Given this list of marker genes Ctnna1, Cap1, Sema6c, Il23a (interleukin 23, alpha subunit p19), Asb2, Gpc1, Emx2, Schip1, Adipoq, Slamf1, Rhoa, Cxcl16, Gnai1 (G protein subunit alpha i1), Idh2, C5ar1, Efnb2, Ephb4, Mcu, Chl1, Lgmn, Plekhg3, Lefty1, Hhipl1, Spred1, Camk2a, Tpm1, Meak7, Park7, Adam15, Prkg1, Strip2, Fbn2, Itgav, Ada, Nox1, Cd200, Fgf3, Ntrk3, Cldn4, Pbxip1, Fndc3b, Prcp, Angpt4, Agtr1a, F11r, Bex6 (NCBI Gene Id 547261), Pdgfc, Anln, Phldb2, Trim32, Ccn4, Lurap1 (leucine rich adaptor protein 1), Gli1, Gba1, Dusp3, Wwc1, Igfbp3, Jun, Gp1ba, Itgb4, Tbx21, Rps19, Sema7a, Iqgap1 (IQ motif containing GTPase activating protein 1), Scrt2, Foxf1, Itga1, Capn1, Parva, Arf6, Gpc4, Fat3, Cnn2, Asap3, Ptp4a3, Tmsb15a, Dcx, Ccl21d, Rap2c, Calr, Plk2, Prkci, Gpr18, Kirrel3, Ptpru, Ntng2 (netrin G2), Epha1, Cep85l, Vegfb, Stc1, Pdgfa, Gm6040, Ifng, Pcdha9, Mmp7, Cln3, Ninj1, Scarb1, Dmrt1, Ddrgk1, Cck, Rarres2, Maz, Cbll1, Xcr1, Pdpn, Ffar2, Bmper, AU040320, Sirt1, Prr5l, Cxcl2, Fermt3, Kitl, F2r, Fga, Hace1, Foxo3, Bmp4 (NCBI Gene Id 12159), Tnf, Pou3f2, Serpine1, Eng, Spdl1 (NCBI Gene Id 76404), Mapre1, Nod2, Fbxo45, Arhgdia, Coro1a, Fgf21, Glipr2, Rere, Bax, Nbl1, Stk39, Cspg4, Ccl21e (NCBI Gene Id 100504239), Spag6l, Emp2, Tmigd1, Ccl24, Lrp1, Pla2g7, Fam89b, Cdh26, Mta2, Irak4, Smoc2, Tubb2a (NCBI Gene Id 263448), Vax1, Plxnd1, Neurog2, Rab1a, Fam3d, Eppk1, Lox, Lypd4, Fer, Fscn2, Fbxo41 (NCBI Gene Id 52369), Arpc5, Six4 (sine oculis-related homeobox 4), Fgfr1, Apoh, Setd2, Ptprb, Afdn, Fuz, Prkcq, Ptprm, Krit1, Arhgap4, Alox5, Ptpn22, Map2k1, Smad2, Rcc2, Slk, Prickle1, S100a11, Cdhr18, Emc10, Ccl25, Prl2c2 (prolactin family 2, subfamily c, member 2), Tesk1, Evx1, Abi2, Gab2, Il1b, Mrtfb, Lamb3, Sema3d, Fgf7, Syk, Tcaf1, Mtor, Unk, Dapk3, Tacstd2, Avl9, Reln, Akt2, Lamtor2, Depdc1b, Prkd2, Tlr4, Cdh2, Lamc1, Pik3r3, Tiam1, Met, Erbb4, Vav3, Dnaaf4, Perp, Srp54a, Ccl5, Add2, Ackr4, Spi1, Hnf4a, Gna13, Ttbk2, Lrch1, Igsf10, Ccl21a, Insr, Ulk1, Prkca, Rac1, Ccl19-ps6, Phox2b (NCBI Gene Id 245706), Arhgef5, Pak2, Tert, Pdlim1, Cdh22, Pik3cb, Mia3, Abl2, Adam10, Itga3, Insl3, Itga4, Cxadr, Bmpr1a, Adipor2, Ythdf3, Nckap1 (NCK-associated protein 1), Anxa1, Cass4, Vegfa, Tnfaip1, Ror2, Flt3, Il24, Paxip1, Smim22, Nup62, Pax3, Mctp1, Miip, Il1rn, Cdh8, Ang6, Rufy3, Sinhcaf (SIN3-HDAC complex associated factor), Mst1r, Itgb1bp1, Magi2, Six2, Dock2, Pak3, Retnlg, Sdc4, Rras (NCBI Gene Id 20130), Dchs1, Jcad, Camk2b, Pgr, Gpsm3, Trem1, Limch1, Sirpa, Gpc3, Angptl3, Usp45, Bcl11b, Pip5kl1, Cklf, Cxcl15, Tgfbr3, Ptger4, Tradd, Smpd3, Cdh15, Ntf3, Adipor1, Fat1, Gdf6, Artn, Sin3a, Tor1a, Pik3r1, Mmp14, Golph3, Mertk, Abr, Auts2, Hrg (NCBI Gene Id 94175), Cend1 (NCBI Gene Id 80544), Kiss1, Cd200r1, Ptprj, Crtam, Ccl28, Egfr, Prkcd, Tgfbr1, Cdkl5, Nkx2-3, Sell, Cxcr3, Pde4b, Nedd9, Tet1, Acan, Ackr2, Pex13, Dll4, Naca, Epx, Nars1, Gcnt2 (NCBI Gene Id 78281), Nexmif, Usp17le, Pik3cg, Trim55, Kiss1r, Bcar1, Disc1, Defb47, Tnc, Casp8 (NCBI Gene Id 12370), Akap12, Svep1, Defb6, Epha8, Spag9, Ptprc, Celsr2, Krt16, Sdc3, Cdk5r2, Ilk, Lyn, Cdh19, Dock7, Plvap, Ceacam1, Pou4f1, Rhof, Abcc8, Fcer1g, Vsir (V-set immunoregulatory receptor), Map3k1, Elp6, Mylk, Akt1, Unc5c, Mif, Lhx6, Ptger3, Mstn, Mapk3, S100a2, Arl13b, Prkcz, Gas6, Egfl7, Cdk5, Nrp2, S1pr2, Trpm2, Numb, Tsc2, Smad4 (SMAD family member 4), S2bpcox16, Ptk2b, Lrp6 (NCBI Gene Id 77387), Mst1, Akirin1, Pacsin2, Pard3, Tirap, Plekhg5, Cib1 (NCBI Gene Id 23991), Cdh10, Cer1 (cerberus 1, DAN family BMP antagonist), Stk4, Rac3, Dysf, Cd24a, Camsap3, Ccn3, Pkn2, Agt, Rbbp4, Abcc1, Mcc, Adam17, St14, Tmsb15b2, Gbf1, Fut10 (NCBI Gene Id 171167), Mapk15, Bbs1, Cxcr2, Jaml, Ric8a, Fam107a, Cxcl1, Ddr1, Megf8, Arrb2, Clec7a, Tnfsf11, Rbfox2, Carmil1, Ston1, Rapgef3, Rps6kb1, Rock1, Fam83h, Ggt5, Sema4f, Fas, Sema5b, Cdh23, Ing2, Cldn13, Fam83d, Arf4, Limd1, Acvr1c, Fut8 (NCBI Gene Id 53618), Scrib, Flna, Irs2, Wnt5a, Pml, Gpr183, Prss37, Gpnmb, Brms1, Podn, Notch1, Ccl21b, Lrp5, Apela, Acp5 (NCBI Gene Id 11433), Xcl1, Enpep, Lcp1, Angpt2, Ccl26, Apcdd1, Rhob (ras homolog family member B), Syde2, Lama3, Nr2f2, Sfrp1, Elp3, Akt3, Tnr, Atp1b2, Trip6, Dpep1, Tgfb1, Cdh11, Gdf15, Ddr2, Cd34, Hspb1, Aimp1, Mgat5, Braf (NCBI Gene Id 97330), Rhbdf1, Sema6a, Pld1, Pvr, Gpc2, Cxcr1, Mark1, Thbs4, Mcoln2, Cav1, Foxg1, Olig3, Sox8, Lemd3, Rab25, Kcnn4, Itga6, Tnfsf4, Onecut2, Pdpk1, Msx2, Ptgs2 (NCBI Gene Id 19225), Cdc42bpa, Dreh, Ptk2, Lamb1, Prtn3, Srf, Dcn, Smad3, Gnrh1, Clasp1, Trpv4, Marveld3, Creb3, Bmp2, Camk2d, Pgf, Vhl (von Hippel-Lindau tumor suppressor), Sox10, Fmnl1, Stat5b, Mnx1, Ccrl2, Tnn, Grem1, Bambi, Cdh3, Tyro3, Mitf, Rap2b, Abhd2, Clxn, Dmtn, Pax6, Rtn4, Jam3, Cpne3, Cxcl13, Il6st, Tff2, Mir218-1, Ccl3, Vtn, Epha3 (Eph receptor A3), Zfand5, Hspa12b, Vcan, Rhog, Bag4, Nr4a1, Ctnnd1, Lima1, Tgfbr3l, Pou3f3, Nfe2l2, Ppp2r3a, Fzd3 (NCBI Gene Id 320969), Ccl6, Hdac7, Cyp19a1, Plaa, B4galt1, Usp33, Ripor2, Tbxa2r, Fut1, Dcc, Barhl2, Cldn19, Rab11a, Fscn3, Wwc2, Cort, Atp8a1, P2ry6 (NCBI Gene Id 66545), Hgf, Patz1, Sox9, Ccl21f, Flrt2, Gata3, Dusp1 (NCBI Gene Id 98098), Tmem18, Cx3cr1, Pds5a, Usp9x, Ndn, Top2b, Madcam1, Tmem196, Ccbe1, Wnt11, Lhx1, Il17a, Gsk3b, P2ry12, Gdf2, Cldn3, Cep85, Wdr47, Adora3, Spn, Mecp2, Ang4, Clec14a, Nrg1, P4hb, Ccr8, Sox14, Adgrg1, Ssh2, Spef1, Plat, P2rx4, Adora1, Dock5, Ptpn23, Cdh5, Dab2ip, Osgin1, Lrig2, Sod2, Fubp1, Scnn1g, Atp7a, Pdilt, Mir504, Ccl4, Postn, Dbh, Pip5k1a (phosphatidylinositol-4-phosphate 5-kinase, type 1 alpha), Lpar1, Vangl2, Ezh2, Ccl19, Mcur1 (NCBI Gene Id 76137), Plxnb2, Msn, Cxcr5, Sema3g, Tfap2a, Pmp22, Meox2, Dock4, Xbp1 (X-box binding protein 1), Fgf2, Clasp2, Ccl2, Apex1, Cxcl11, Sp1, Trib1, Mospd2, Fgr, Vcam1, Muc2, Plec, Bmerb1, Ntn1, Reck, Ppbp, Emilin2, Sparc, Lgals9, Cdh18, Ccl19-ps3, Itga9, Hexb, Ptp4a1, Dock8, Thy1, Ccn1, Tbx20, Tac1, Sox17, Nlrp3, Fpr-rs7, Ppargc1a, Amot, Mdga1, Wasf2, Cldn1, Plxnb3, Flt1, Drd4, Fignl2, Cd9, Coro1b, Ndel1, Nfix (NCBI Gene Id 18032), St3gal4, Fat2, Shtn1, Sema3b, Mapre2, Phactr4, Tubb2b, D130043K22Rik, Lmx1b, Crb2, Cntn2, Tafa4 (NCBI Gene Id 320701), Itgb8, Itga2b, Cul5, Sema3e, Flt4, Aoc3, Mmp10, S100a14, Cenpv, Gja1 (gap junction protein, alpha 1), Cxcl5, Ccr7, Rras2, Ednrb, Wdr1, Itgb7, Cdh24, Pdcd6, Cxcl10, Wincr1, Gpx1, Col5a1, Vinac1, Tmigd3, Ddit3, Sphk1, Ogdh, Hyal2, Rnf41, Elp5, Tmem102, Lmo4, Scg2, Cd81, Lrrc15, Hmgb2, Tns3, Mir875, Ptprg, Evl, Cx3cl1, C5ar2, Hc, Trem3, Fktn, Sun2, Ptprf, Ccl11, Il1a, Zpld2, Shroom2, Ace, Rnf7, Pik3r2, Tlx3, Retn, Fut7, Nav1, Ldb2, Foxj1, Uts2 (NCBI Gene Id 24111), Med23, Stap1, Ripor1, Fstl1, Kif2a, Krt5, Pawr, Knstrn, Myoc, Apod, Plet1, Nr2e1, Actr3, Dcdc2a, Nrg3, Acvr1b, Rnf20, Nkx2-1, Plxna3, Gm5849, Igfbp5, Fmn2, Radil, Trim46, Umod, Tafa5, Cd47, Edn3, Prl7d1, Mdm2, Angpt1, Grb7, Cripto, Csnk2b, Zmynd8, Atn1, Cttn, Tacr1, Plekho1, Nrp1, Ptprk, Pde4d, Psen1, Atp5f1b, Lgr6, Sema3f, Plpp3, Egf, Phactr1, Vav1, Dab1, Sh3rf1, Fermt2, Sbpl, Enpp2, Gpc5, Dnai3, Prpf40a, Padi2, Myo1f, Arid2, Hdac4, Fgfr4, Fpr-rs6, Nsmf, Actg1, Defb5, Peak1, Thbs1, Mmp2, Cxcr6, Il16, Slc8b1, Has1, Eomes, Errfi1 (NCBI Gene Id 74155), Emilin1, Rin3, Arsb, Arpin, Mmrn1, Fbxw7, Mrtfa, Lyst, Pten, Mark2, Synpo2, Zfp640, Ptk6, Lbp, Cdh1, Hcls1, Fgf5, Ccl19-ps5, Satb2, Lrg1, Gm266, Apbb2, Ext1, Nck2, Pdgfrb, Igf2, Cxcl9, Synj2bp, Lyve1, Robo1, Macf1, Sp100, Slc8a1, S100a8, Cd74, Six1, Pdgfra, Cnr2, Rnh1, Cxcl14, Cyp7b1, Sap130, Nav3, Dpp4, Card10, Ch25h, Slit2, Ifnb1, Map3k3, Plxnb1, Sap30, Tnfrsf14, Vav2 (vav 2 oncogene), Arhgef2, 4930544G11Rik, Ccl7, Ldb1, Ajuba, Pik3c2a, Fbxo31, Adra2a, Ccl19-ps1, Pdgfd, Plxnc1, Nrtn, Cdc42bpb, Tbccd1, Ednra, Arhgef39, Gpr15, Cd99l2, Mapk8, Map3k7, Nodal, Sele, Katna1, Snai2, Wnk1, Gstp1, Six3, Slamf9, Sema4b, Wdpcp, Saa3, Col18a1, Gli3, Slamf8, Il34, Adarb1, Rac2 (Rac family small GTPase 2), Ntn4, Cited2, Pex7, Prr5, Hdac9, Sec1, Ccar1, Spns2, Epha4, Ssh1, Mtch2, Gfra1, Mmp9, Bmpr2 (bone morphogenetic protein receptor type 2), Vegfd, Sema4g, Pex2, Cxcl12, Lmna, Cyp1b1, Arpc2, Wdr44, Dlg5, Cdh12, Capn7, Sst, Ntng1, Nipbl, Mesp2, Plau, Cpeb1, Gpc6, Nf1, Zranb1, Selp, Apoa1, Tek, Lrp12, Vrk1, Sh3bp1, Sh3rf2, Rab13, Mmrn2, Gpi1, Ccdc88a, Misp, Pcnt, Ptpn11, Bin2, Hdac5, Smarca4 (NCBI Gene Id 20586), Sorl1, Septin14, Itgb2l, Folr1, Mmp28, Ptprz1, Klf4, Trem2, L1cam, Crk (v-crk avian sarcoma virus CT10 oncogene homolog), S100a11-ps, Hdac2, Tmem201, Bmp7, Fezf2, Myc, Cxcl3, Bves, Fpr2, Ogt, Sbp, Bmp10, Srgap2, Stat3, Mdk, Mtus1, Arhgap24, Defb8, Cthrc1, Dnaja4, Nde1, Foxo4, Prox1, Cckar, Lep, Cd300a, Kcnq1ot1, Ccl19-ps4, Epb41l5, Srcin1, Cul3, Ptpn1 (NCBI Gene Id 19246), S100a9, Cygb, Arpc5l, Fgf1, Mgat3, S100a7a, Arid5b, Irs1, Dsg3, Igf1r, Zfp609, Syde1, Gcsam, Hif1a, Wnt7a, Gpr15lg, Sh3kbp1, Srpx2, Jam2, Tuba1a (NCBI Gene Id 22142), Cadm1, Plcg2, Rhoj, Celsr1, Myh9, Zp3, Daam2, Grin1, Mapk8ip3, Grb10, Svbp, Sash1, Cers2, Appl2, Gfus, Ripk3, Septin4, Elmo2, Syne2, Ptpro, Ecm1, Arid4b, Adam8, Ccl27a, Sema3a, Osbpl8, Agtr1b, Chrd, Clic4, Bsg, Gbx2, Pld2, Chga, Il17b, Ascl2, Pi4ka, Foxn1, Jup, Defb4 (NCBI Gene Id 66348), Apc2, Htr6, Actn4, Podxl, Rock2, Sdc1, Arhgdib, Scrt1, Itgb6, Ephb3, Il12b, Ube2i, Efnb1, Sbds, Flrt3, Atm, Mapk1 (mitogen-activated protein kinase 1), Erdr1, Zeb2, Fam114a1, Cd151, Ano6, Itgal, Prag1, Tmsb15b1, Drd1, Smo, Rhoc, Fut4, Pomgnt2, Amotl2, Pitx2, Ccr5, Dixdc1, Twist1, Adamts12, Gab1, Arhgef16 (NCBI Gene Id 638799), Ccl9, Vcl, Il17ra, Bex4, Mink1, Frmd5, Cmklr1, Bcr, Ccdc141, Fam110c, Spata13, Fut9, Mef2c, Isl1, Twist2, Defb7, Htr2b, Ang, Il33, Dapk2, Megf9, Ngfr (nerve growth factor receptor (TNFR superfamily, member 16)), Camk1d, Serpinf1, Zfp950, Pecam1, Zmiz1, Hsd3b7, Coro7, Enpp1, Ackr3, Fpr-rs4, Csf1, Epha2, Ctnna2, Ccl20, Map4k4, Wnt5b, Cdk5r1, Cxcl17, Acvrl1, Aspm, Plp1, Dock1, Edn2, Gdnf, Tnfaip3, Hspa5, Pkp2, Agr2, Sulf1, Plxna4, Mixl1 (Mix paired-like homeobox), Anxa3, Nherf1, Mcam, Trp53, Drd2, Foxp1, Hoxa5, Coro6, Pik3c2g, Gpr35, Zfp580, Ang5, Aire, Swap70, Selenok (selenoprotein K), Mapt, Abhd6, Spry2, Robo4, Nos3, Stmn1, Pfn1, Fgf6, Gp2, Fermt1, Rpl13a, Tspo, Brms1l (NCBI Gene Id 71698), Kank1, Arhgef7, Atoh8, Robo3, Sun1, Sh3d21, Foxc2, Hdac1, Kctd13, Sox18, Trpm4, Bcl2, Tnfrsf12a, P2ry1, Oxsr1, Il27ra, Kdr, Cd248, Ntrk2, Vegfc, Ovol2, Pcsk5, Rack1, Rapgef4, Neurod4, Ephb1, Ptprt, Ccn2, Sema6d, Bcas3, Nus1, Ccl8, Amotl1, Vstm4, S1pr1, Arx, Gata2, Ppp3ca, Il12a, Lgals8, Nisch, Defb46, Macir, Esr2, Nkx6-1, Lama1, C1qbp, Nfatc2, Bin3, Cxcr4, Ctsh, Fgf9, Astn1, Tmeff2, Cdc42, Jag1, Ets1, Dach1, Egr3, Wasl (NCBI Gene Id 73178), Megf10, Fgf16, Sema4c, Wnt4, Fgf15, Has2, Rreb1, Iqsec1, Dlc1 (NCBI Gene Id 50768), Cd69, Slc12a2 (NCBI Gene Id 20496), Dpysl3, Arhgap5, Ang2, Msmp, Tcp11l2, Efhc1, Fezf1, Ywhae, Scnn1b, Fbln1, Lcn2, Myocd, Mpp1, Adora2b, Fyn, Barhl1, Zfp703, Sdccag8, Gper1, Fgf18, Rbbp7, Abl1 (c-abl oncogene 1, non-receptor tyrosine kinase), Alkbh1, Edn1, Pdgfb, Pikfyve, Atp5f1a, Rin2, Vash1, Efna1, Zc3h12a (zinc finger CCCH type containing 12A), Fmnl3, Il17rc, Palld, Prkd1, Diaph1, Cdkn1b, Foxc1, Lef1, Mmp3, Suds3, Ndnf, Fap, Itga2, Igf1, Plcg1, Gipc1, Ccr1l1, Cyrib, Ndrg4, Col1a1, Ccr4, Pik3ca, Myh10, 2610005L07Rik, Usp9y, Foxb1, Gsx2, Ankrd11, Lgals3, Pik3cd, Tmsb4x, Stk26, Nr4a3, Prkce, Il1r1, Defb33, Tbx5, Lama4, App, Rdx, Apoe, Ctnna3, Fadd, Nhlh2, Phlda2, Itga11, Cdh6, Mdga2 (NCBI Gene Id 320772), Lamc2, Gtpbp4, Plxna2, Mesp1, Dusp22, Ppia, Tgfbr2, F3, Cdh20, Pparg, Slit1, Rasgef1a, Sap30l, Crkl, Bst1, Defb3, Carmil3, Tmsb10, Sema4a, Rap2a, Cldn5, Lama5, Bst2, H2bc1, Ccr2, Cd44, Loxl2, Hmgb1, Lamb2, Grn, Ifitm1, Coro1c, Fgf13, Nck1, Rabgef1, Phb2, Slurp1, Efs, Cdh17, Ccr10 (NCBI Gene Id 12777), Hand2, Fmnl2, Stk24, Pkn3, Nlrp12, Mir124a-1hg, Mysm1, Kank2, Defb14, Tlr2, Spock1, Itgam, Furin, Dnm1l, Carmil2, Acta2 (NCBI Gene Id 68377), Cd274, Srgap3, Ldlrad4, Ccr6, Pex5, Bbs4, Mien1, Tgfb2, Sox1, BC037156, Myo18a, Aif1, Tjp1, Gstp2, Cemip (cell migration inducing protein, hyaluronan binding), Lama2, Atp2b4, Igfbp6, Ephb2, Itgbl1, Itgb5, Cdh9, Smurf2, Ltb4r2, Itgb3, Zswim6, Atoh1, Vim, Nog, Rgcc, Rffl, Itgb2, Myadm, Fgf10, Tie1, Ret, Aqp1, Spp1, Axl, Adgrl3, Itga5, Hyal1, Kit, Ptprr, Fgf8, Gm28729, Ddit4 (DNA-damage-inducible transcript 4), Lrp8, Jagn1, Mir218-2, Selplg, Cd40, Map2k5, Ccl22, Ptk7, Map2k3, Pcm1, Dab2, Sema6b, Socs7, Aldoa, Hbegf, Foxe1 (NCBI Gene Id 242422), Fgf17, Ppm1f, Src, Astn2, Stx4a, Krt2, Dag1, Dclk1, Sema3c, Ccr9, Apc, Gpm6a, Rapgef2, Micall1, Rigi, Ccr3, Nup85, Cfl1, Itga7, Slc37a4, Adgrg3, Tnfrsf18 (tumor necrosis factor receptor superfamily, member 18), Hes1, Cd177, Myd88, Plxna1, Nox4, P2ry2, Mboat7, Fn1, Eps8, Hoxa7, Tnfsf14, Jak2, Nanos1, Unc5d, Vil1, Tbc1d24, Adamts9, Ppib, Abi3, Fkrp, Ehd4, F2rl1, Pkn1, Hdac6, Fcgr3, Sin3b, Ing1, Csf3r, Stk10, Lrrk2, Drgx, Insm1, Sfrp2, Snai1, Dock10, Il18, Fgf20, Ccl17, Hoxb9, Arid4a, Or51e2, F7, Ppp1r9b, Tbx1, Gpld1, Bdkrb1, Csf2, Fzd4, Large1 (NCBI Gene Id 17871), Pafah1b1, Defb48 (NCBI Gene Id 432867), Col3a1, Prkx, Pak1, Sdc2, Mmp12, Gnai2, Celsr3, Matn2, Fgfbp1, Hras, Hsp90aa1, Myo9b, Appl1, Sgpl1, Trp53inp1, Ppard, Cep43, Abi1, Myo1g, Plcb1, Tns1, Glul (NCBI Gene Id 226521), Defb25, Myo5a, Pik3c2b, Anks1, Stard13, Drd5, Cd2ap, Nckap1l, Arc, Pxn, Ager, Tpbg (trophoblast glycoprotein), Arhgap35, Ptafr, Kif20b, Ccr1, Fgf23, Plg, Fbxo5, Nr2f1, Pycard, Prex1, Specc1l, Elane, Apbb1, Fscn1, Ccl1, Adgrb1, C3ar1, Gpr173, Cd63, Gcnt1, Ascl1, Alox12, Sdcbp, Hmox1, Ccl12, Gsk3a, Lpxn, Rhod, Gna12 (NCBI Gene Id 14673), Il4, Adgra2, Cdh4, Fgf22, T, Ptn, Timp1, Sstr4, Srgap1, Acap3, Neo1, Chst2, Efemp1, Cdh7, Wdr62, Pfn2, Kif26a, Gfra3, Scai, Onecut1 (one cut domain, family member 1), Dicer1, Fgf4, Nexn, Pdcd10, Brat1, Adam9, Chst4, Myo1c, Cdh13, Podxl2, Ulk4, Gadd45a, Nr4a2, Itgb1, Arhgap32, Klrk1, Tnfsf18 (tumor necrosis factor (ligand) superfamily, member 18), Dubr, Dusp10, Itgax, Egr1, Epb41l4b, Shh, Sema4d, Kif14, Stat5a, Net1, Prop1, Ctnnb1, Filip1, Acvr1, Fpr-rs3, Adamts1, Pf4, Adtrp, Mmp1a, Tnfaip6, Tubgcp2, Ctsg, Csf1r, Ago2, Sema5a, Icam1, here is a description of the gene set: The controlled self-propelled movement of a cell from one site to a destination guided by molecular cues. Mouse Gene Set: GOBP_CELL_MIGRATION studied in species Mus musculus